Given this list of marker genes EXO1, HOXB7 (NCBI Gene Id 3217), CPD, TARDBP, FRZB, TBC1D1, BMP4, GART, SSH1, SETD7 (SET domain containing 7, histone lysine methyltransferase), NHERF1, APLN, NRARP, SKIL, RCC2, SRSF5, CDS2, MGAT4B, IFI30, AKAP8, LZTR1, RAD23B, CD276, PMP22, ARL4C, ACP1, LPCAT1, TEX30, TXNIP, ETS2, MYH9, ZMAT3, CDC25A, STXBP5, NSL1, CACNA1H, G3BP1, MAT2A, CHN2, IRGM, MOGS, IFIT1B, PYCR2, CCND1, IL1R1, AMD1 (NCBI Gene Id 262), SRSF10, CACYBP, PRPF19, TRIM21, ELOVL1, TK2, UBE2C, IFNGR2, RAPGEF3, SRSF7, H2AJ, USP46, FRRS1, PLXNA1, MMP8, LSM2, FAS, MAP3K11, NOTCH1 (NCBI Gene Id 54781), CDK2AP1, SAC3D1, TOPBP1, LGALS3BP, TMEM176A, ATP1B3, AGRN, CASP3, TNRC6A, PLEC, RRM2, F2R, SEPHS2, CCNB1, GET1, MGAT2, SGO1, GADD45G, BCL6B, SRSF1, DIDO1, PPAT, CAMKK2, SIGMAR1, IL18, HACD3, KPNA2, SSBP3, COL4A2, ELOVL6, RXRA, H6PD, RAD1, DUSP7, SRSF2, TNS1, GNA11, GATA2, here is a description of the gene set: Human Gene Set: GROSS_HYPOXIA_VIA_ELK3_AND_HIF1A_DN Genes down-regulated in SEND cells (skin endothelium) at hypoxia after knockdown of ELK3 and HIF1A by RNAi. species: Mus musculus The ternary complex factor Net/Elk3 is downregulated in hypoxia and participates in the induction by hypoxia of several genes, including c-fos, vascular endothelial growth factor and egr-1. However, the global role of Net in hypoxia remains to be elucidated. We have identified, in a large-scale analysis of RNA expression using microarrays, more than genes that are regulated by Net in hypoxia. In order to gain insights into the role of Net in hypoxia, we have analysed in parallel the genes regulated by HIF-1alpha, the classical factor involved in the response to hypoxia. We identified about genes that are regulated by HIF-1alpha in hypoxia. Surprisingly, when we compare the genes induced by hypoxia that require either Net or HIF-1alpha, the majority are the same (75%), suggesting that the functions of both factors are closely linked. Interestingly, in hypoxia, Net regulates the expression of several genes known to control HIF-1alpha stability, including PHD2, PHD3 and Siah2, suggesting that Net regulates the stability of HIF-1alpha. We found that inhibition of Net by RNAi leads to decreased HIF-1alpha expression at the protein level in hypoxia. These results indicate that Net participates in the transcriptional response to hypoxia by regulation of HIF-1alpha protein stability. from publication Gross C, Dubois-Pot H, Wasylyk B (PMID 17704799)